Given this list of marker genes Ms4a13, Nrf1, Nxph1, Aph1a, Ireb2, Fkbp1b, Mvb12b, Abca3, Ube2d2a, Cic, Nr4a3, Birc6, Fam168a, Atp1b1, Ddx25, Zfp616, Prdm16, Pank1, Usp31, Eras, Kcnq4, Rph3al, Emilin3, Klf4, Aff4 (NCBI Gene Id 93736, AF4/FMR2 family, member 4), Mettl25b (methyltransferase like 25B), 9930012K11Rik, Bdnf, Fkbp9, Fryl, Pax9, Ret, Plekha8, Syne1, Unc50, Psd3, Adcy9, Cd1d1, Lgalsl, Hsd17b6, Atp1b3, Arl13b, Ppp1r3c, Kcnj6 (NCBI Gene Id 547288), F3, Kalrn, Kansl3, Il13 (NCBI Gene Id 16163, interleukin 13), Uroc1, Spta1, Znrf1, Chmp7, Rubcnl, Slmap, Sgms1, Cdc42se1, Nde1, Setx, Usp25, Setbp1, Crocc2, Rock2, Crlf3, Dock4, here is a description of the gene set: from publication Chen Y, Wang X (PMID 31504780) Genes predicted to be targets of miRBase v22 microRNA mmu_miR_7019_3p in miRDB v6.0 with MirTarget v4 prediction scores > 80 (high confidence targets). species: Mus musculus Mouse Gene Set: MIR_7019_3P